Given this list of marker genes Cadm1, Map4k4, Idh3b, Kcnma1, Lrp1b, Camk2g, Chl1, Sptan1, Bptf, Tacc2, Atp2b1, Plcb4, Cask, Kcnq2, Cacna1b, Epb41l2, Dnajb5, Epb41, Efna5, Epha5, Ncdn, Ntng1, Gpr45, Tpm3, Stxbp2, Srr, Grin1, Ctnna2, Ptprf, Arhgap21, Aplp2, Epb41l3, Clstn1 (NCBI Gene Id 74323), Lrp12, Grik2, Gphn, Clasp1, Ank3, Golga4, Agrn, Mapk8ip1, Rap1gap, Stx2 (NCBI Gene Id 269706), here is a description of the gene set: Alternative RNA splicing greatly increases proteome diversity and may thereby contribute to tissue-specific functions. We carried out genome-wide quantitative analysis of alternative splicing using a custom Affymetrix microarray to assess the role of the neuronal splicing factor Nova in the brain. We used a stringent algorithm to identify 591 exons that were differentially spliced in the brain relative to immune tissues, and 6.6% of these showed major splicing defects in the neocortex of Nova2-/- mice. We tested 49 exons with the largest predicted Nova-dependent splicing changes and validated all 49 by RT-PCR. We analyzed the encoded proteins and found that all those with defined brain functions acted in the synapse (34 of 40, including neurotransmitter receptors, cation channels, adhesion and scaffold proteins) or in axon guidance (8 of 40). Moreover, of the 35 proteins with known interaction partners, 74% (26) interact with each other. Validating a large set of Nova RNA targets has led us to identify a multi-tiered network in which Nova regulates the exon content of RNAs encoding proteins that interact in the synapse. Genes whose splicing in neocortex was most affected by knock out of NOVA2. from publication Ule J, Ule A, Spencer J, Williams A, Hu JS, Cline M, Wang H, Clark T, Fraser C, Ruggiu M, Zeeberg BR, Kane D, Weinstein JN, Blume J, Darnell RB (PMID 16041372) studied in species Mus musculus Mouse Gene Set: ULE_SPLICING_VIA_NOVA2